The following is a description of a gene set: The chemical reactions and pathways involving leukotriene B4, a leukotriene composed of (6Z,8E,10E,14Z)-eicosatetraenoic acid having (5S)- and (12R)-hydroxy substituents. Mouse Gene Set: GOBP_LEUKOTRIENE_B4_METABOLIC_PROCESS studied in species Mus musculus, and this is the list of marker genes: Cyp4f18, Cyp4f15, Ptgr1, Cyp4f13, Cyp4f40, Cyp4f14